Given this list of marker genes DVL1, NTRK3, NRCAM, CDKL5, MAG, SEMA6C, SLC23A2, KIAA0319, EIF2AK4, SEMA6D, FLRT1, ITGA4, CPNE5, DISC1, CDK5, EMX1, CYFIP2, PTPRS, RAB21, EDN3, CLSTN3, MAPT, NTN1, AUTS2, VCL, MEGF8, LAMB2, L1CAM, DSCAM (DS cell adhesion molecule), BARHL2, IFRD1, PRKN, TTL, CTNNB1, STK11, ZFYVE27, NDEL1, GOLGA4, SEMA5B, AURKA, NRN1L, C9orf72, ANAPC2, OLFM1, GAREM2, PAFAH1B1, TNFRSF12A, SSNA1, ADNP, NRP1, PLXNA3, APOE, HDAC6, SEMA5A, SEMA3F, ADCY10, SLITRK1, PAK1, PLXNA1, DIP2B, GSK3B, EDN2, CDKL3, OSTN, S100B, EDN1, NGF (nerve growth factor), ITGB1, SYT3, EDNRA, RTN4R, RASAL1, SH3GL2, MACF1, POSTN, ULK2, LHX2, ATG16L1, UNC13A, SLC9A6, LIMK1, LLPH, ARHGAP4, RUFY3, DNM2, NEDD4L, SYT17 (NCBI Gene Id 51760), DDR1, WASF1, POU4F3, CTTN, NLGN3, MAP2, TWF2, FLRT3, PLXNA4, PRKCZ, SMURF1, SEMA3A, SEMA3G, DRAXIN, IQGAP1, NRN1, DCLK1, SYT14P1, RIMS1, RNF157 (NCBI Gene Id 114804), SRF (serum response factor), USP9X, PPP3CB, CDH1, NKX6-1, CDH4, SYT4, CLASP2, TNR, PRICKLE1, SLIT2, WNT5A, CYFIP1, PAK6, MUL1, SLIT3, SYT1, CPNE6, SPG11, ISLR2, ALCAM, IMPACT, SEMA4F, NRP2, SLC39A12, MAP3K13, TSC22D4, SPAG9, TRPV2, BMPR2, CXCL12, SHTN1, PLAA, GDI1, WNT3A, FN1, WNT3, POU4F2, SEMA7A, RTN4, SIN3A, TMEM108, ULK1, CACNG7, ABL1, RYK, MT3, TNN, SPAG6, ST8SIA2, SLIT1, RIMS2, SYT2, VEGFA, RNF6, CPNE1, BCL11A, ITSN2, RAPH1, TRIM46, MAP1B, TRPC5, CPNE9, NDN, here is a description of the gene set: studied in species Homo sapiens Long distance growth of a single neuron projection involved in cellular development. A neuron projection is a prolongation or process extending from a nerve cell, e.g. an axon or dendrite. Human Gene Set: GOBP_NEURON_PROJECTION_EXTENSION